Given this list of marker genes CTLA4, FOXN1, IL7R, CD247, CD3E, ZAP70, RFXAP, RFXANK, CIITA, ZBTB24, BTD, GJB6, IL12RB1, CD3D, RFX5, GJB2, DOCK8, SLC39A4, here is a description of the gene set: species: Homo sapiens Human Gene Set: HP_RECURRENT_CANDIDA_INFECTIONS Recurrent candida infections An increased susceptibility to candida infections, as manifested by a history of recurrent episodes of candida infections.